Given this list of marker genes NKX2-6, NADSYN1, CIROP, LZTR1, PLXND1 (plexin D1), POLR1A, TBX5, TBX1, here is a description of the gene set: Human Gene Set: HP_ABNORMAL_CORONARY_ARTERY_ORIGIN studied in species Homo sapiens Abnormal coronary artery origin Isolated abnormalities of the coronary artery origins. This may be in associated with other structural heart malformations but not the patterns of complex structural heart malformations which result in abnormal course of the coronary arteries.